Given this list of marker genes Nlrp4c, Irf3, Sting1, Tbk1, Dtx4, here is a description of the gene set: Mouse Gene Set: REACTOME_IRF3_MEDIATED_INDUCTION_OF_TYPE_I_IFN IRF3-mediated induction of type I IFN species: Mus musculus